The following is a description of a gene set: studied in species Homo sapiens RHOB GTPase cycle Human Gene Set: REACTOME_RHOB_GTPASE_CYCLE, and this is the list of marker genes: DAAM1, SOWAHC, ARHGEF10L, RHOB, MYO9B, TFRC, PKN3, ERBIN, PREX1, VAV2, MCAM, STARD13, CIT, ARHGAP1, BCR, PKN2, DLC1, ARHGEF5, ARHGAP35, ACTC1, FLOT2, SLK, ARHGAP21, PIK3R2 (phosphoinositide-3-kinase regulatory subunit 2), ARHGEF17, MCF2L, AKAP13, NET1, ARHGEF3, ARHGEF28, ARHGAP32, VAMP3, ROCK2, VANGL1, JUP, ARHGEF25, CAVIN1, CAV1, DEPDC1B, ARHGAP39, DIAPH3, IQGAP3, ARHGAP5, ROCK1, ARHGEF1, RACGAP1, ARHGEF12, PKN1, MYO9A, ARHGAP26, ARHGEF10, STK10 (NCBI Gene Id 729035), RHPN2, ARHGDIG, ANLN, SNAP23, STARD8, ARHGEF2, MCF2, RTKN, FLOT1, DIAPH1, OPHN1, PIK3R1, PCDH7, TJP2, ECT2, ABR, ARHGEF11, STOM